The following is a description of a gene set: studied in species Homo sapiens Any process that modulates the frequency, rate or extent of synaptic vesicle recycling. Human Gene Set: GOBP_REGULATION_OF_SYNAPTIC_VESICLE_RECYCLING, and this is the list of marker genes: BTBD9, STX1B, PARK7 (NCBI Gene Id 113880, Parkinsonism associated deglycase), SYT11, VAMP4 (NCBI Gene Id 8674), AP2M1, CALM3, OPHN1, ROCK1, NLGN1, PLAA, RAC1, ACTG1, CDK5, SLC17A7, SYT7, MYLK, PPP3CC, TOR1A, PPP3CB, ACTB, LRRK2, ABCA13, GRIPAP1, ARPC3, PRKN, SNX9, DGKQ, SNCA